Given this list of marker genes Calr, Sart1, Serinc3, B2m, Aff3, Syt13, Cldnd1, Snrnp70, Zmynd8 (NCBI Gene Id 99150), Cavin2, here is a description of the gene set: from publication Schaeffer EM, Marchionni L, Huang Z, Simons B, Blackman A, Yu W, Parmigiani G, Berman DM (PMID 18794802) Mouse Gene Set: SCHAEFFER_PROSTATE_DEVELOPMENT_AND_CANCER_BOX1_DN Early prostate development genes (down-regulated at 6 h dihydrotestosterone) which are also down-regulated in normal epithelium vs high grade prostatic intraepithelial neoplasia (PIN). species: Mus musculus Cancer cells differentiate along specific lineages that largely determine their clinical and biologic behavior. Distinct cancer phenotypes from different cells and organs likely result from unique gene expression repertoires established in the embryo and maintained after malignant transformation. We used comprehensive gene expression analysis to examine this concept in the prostate, an organ with a tractable developmental program and a high propensity for cancer. We focused on gene expression in the murine prostate rudiment at three time points during the first 48 h of exposure to androgen, which initiates proliferation and invasion of prostate epithelial buds into surrounding urogenital sinus mesenchyme. Here, we show that androgen exposure regulates genes previously implicated in prostate carcinogenesis comprising pathways for the phosphatase and tensin homolog (PTEN), fibroblast growth factor (FGF)/mitogen-activated protein kinase (MAPK), and Wnt signaling along with cellular programs regulating such 'hallmarks' of cancer as angiogenesis, apoptosis, migration and proliferation. We found statistically significant evidence for novel androgen-induced gene regulation events that establish and/or maintain prostate cell fate. These include modulation of gene expression through microRNAs, expression of specific transcription factors, and regulation of their predicted targets. By querying public gene expression databases from other tissues, we found that rather than generally characterizing androgen exposure or epithelial budding, the early prostate development program more closely resembles the program for human prostate cancer. Most importantly, early androgen-regulated genes and functional themes associated with prostate development were highly enriched in contrasts between increasingly lethal forms of prostate cancer, confirming a 'reactivation' of embryonic pathways for proliferation and invasion in prostate cancer progression. Among the genes with the most significant links to the development and cancer, we highlight coordinate induction of the transcription factor Sox9 and suppression of the proapoptotic phospholipid-binding protein Annexin A1 that link early prostate development to early prostate carcinogenesis. These results credential early prostate development as a reliable and valid model system for the investigation of genes and pathways that drive prostate cancer.